Given this list of marker genes Rlbp1, Opn4, C8g, Aldh1a2, Ptgds (NCBI Gene Id 19215), Lrat, Rara, Coq9, Akr1b8 (aldo-keto reductase family 1, member B8), Cyp26c1, Rxra, Nr2f2, Rbp3, Abca4, Stra6, Fabp5, Rbp2, Adh7, Opn3, Rbp1, Lcn12, Ugt1a7c, Ugt1a1, Adh4, Opn5, Crabp2, Cyp2w1, Ugt1a8, Cyp26b1, Ugt1a2, Or1j21, Rbp7, Crabp1, Ugt1a9, Lcn5, Serpina5, Rho (rhodopsin), Rbp4, Ugt1a10, Or6e1, Rabggtb, Cyp26a1, Igf2r, here is a description of the gene set: Binding to an isoprenoid compound, isoprene (2-methylbuta-1,3-diene) or compounds containing or derived from linked isoprene (3-methyl-2-butenylene) residues. Mouse Gene Set: GOMF_ISOPRENOID_BINDING species: Mus musculus